Given this list of marker genes STAT3, STAT1 (NCBI Gene Id 6772), JAK2, IL20RB, JAK1, JAK3, IFNL3, IL19, TYK2, PTPN11, IFNL2, IFNLR1, IFNL1, IL26, IL22RA2, IL20RA, IL22, IL22RA1, STAT4, STAT5B, IL24, IL20, STAT5A, SOCS3, IL10RB, STAT2, here is a description of the gene set: studied in species Homo sapiens part of: Signaling by Interleukins The interleukin 20 (IL20) subfamily comprises IL19, IL20, IL22, IL24 and IL26. They are members of the larger IL10 family, but have been grouped together based on their usage of common receptor subunits and similarities in their target cell profiles and biological functions. Members of the IL20 subfamily facilitate the communication between leukocytes and epithelial cells, thereby enhancing innate defence mechanisms and tissue repair processes at epithelial surfaces. Much of the understanding of this group of cytokines is based on IL22, which is the most studied member. Reactome Pathway: Interleukin-20 family signaling